The following is a description of a gene set: Human Gene Set: FLORIO_NEOCORTEX_BASAL_RADIAL_GLIA_DN Evolutionary expansion of the human neocortex reflects increased amplification of basal progenitors in the subventricular zone, producing more neurons during fetal corticogenesis. In this work, we analyze the transcriptomes of distinct progenitor subpopulations isolated by a cell polarity-based approach from developing mouse and human neocortex. We identify genes preferentially expressed in human apical and basal radial glia that lack mouse orthologs. Among these, ARHGAP11B has the highest degree of radial glia-specific expression. ARHGAP11B arose from partial duplication of ARHGAP11A (which encodes a Rho guanosine triphosphatase-activating protein) on the human lineage after separation from the chimpanzee lineage. Expression of ARHGAP11B in embryonic mouse neocortex promotes basal progenitor generation and self-renewal and can increase cortical plate area and induce gyrification. Hence, ARHGAP11B may have contributed to evolutionary expansion of human neocortex. species: Homo sapiens Genes down-regulated in basal radial glia (bRG) relative to apical radial glia (aRG), and up-regulated in both aRG and bRG relative to neurons. from publication Florio M, Albert M, Taverna E, Namba T, Brandl H, Lewitus E, Haffner C, Sykes A, Wong FK, Peters J, Guhr E, Klemroth S, Prüfer K, Kelso J, Naumann R, Nüsslein I, Dahl A, Lachmann R, Pääbo S, Huttner WB (PMID 25721503), and this is the list of marker genes: E2F8, GAS2L3, KIFC1, SLC35G2, CDCA2, MYBL2, KIF4A, KIF15, NUF2, CENPU, TRAIP, CKS2, FAM124B, SPAG5, HBG1, FBXO5, ARHGAP11A, IQGAP3 (IQ motif containing GTPase activating protein 3), CDCA5, TTK, DEPDC1, RAD51AP1, FAM72B, BIRC5, CCNB2, POC1A, BUB1B, TGIF1, EDNRB, TPX2, CENPK, HAPLN1, FOXM1, BRCA1 (BRCA1 DNA repair associated), PRC1, CENPL, SHCBP1, HBA1, BRCA2, CKS1B, AK4, ARHGAP19, ACBD7, TOP2A, ZWINT, KIF11, POGLUT3, LUM, SERTAD4, CCNA1, COL1A2, NUSAP1, TRIM59, HMGN2, NEMP1, MIS18BP1, TK1, VCAM1, PHGDH, KIF23, MKI67, LDLR, BUB1, CENPF, CKAP2, CENPE, CHEK2, PTTG1, TROAP, GRIN2A, SKA3, SGO2, CENPA, CDCA3, MCC, BLM, SEMA5A, NID1, TIMELESS, SGO1, APOD, FAM72D, MAD2L1, ESCO2, WEE1, TACC3, NDE1 (nudE neurodevelopment protein 1), KIF22, FANCI, ATP9B, DTL, CDC45, HMGB2, CDCA8, NCAPH, EMP1, TUBB6, CEP152, PARPBP (NCBI Gene Id 55010), DSN1 (DSN1 component of MIS12 kinetochore complex), UBE2C, CCNB1, LMNB1, PLK1, CENPM, ESPL1, PRR11, GINS1, SULT1C4, C5, ANLN, KIF20A, KNSTRN, DUSP10, KIF18B, ITM2A, KIF14, TFPI, GEM, UBE2T, RFTN2, MELK, FSTL1, EXPH5, CKAP2L, UGT8, IL32, KIF2C, EPB41L2, HSD17B11, KPNA2, PSRC1, AURKA, SKA1, LRP4, SPC25, CDK1, NSUN7, RACGAP1, NEK2, XRCC2, NDC80, SLC15A2, SPARC, KIF18A, PLK4, H1-1, CDC20, CIP2A, ANXA1, POLQ, PBK, EPCIP, PCDH11X, MSH5, TENT5C, FGFR2, MFAP4, PDGFD, HJURP (NCBI Gene Id 55355, Holliday junction recognition protein), FN1, GTSE1, MND1 (meiotic nuclear divisions 1), ANP32E, BRIP1, ANO5, RRM2, KNTC1, DLGAP5, NCAPD2, DEPDC1B, TMEM47, EXO1, HMMR, PRELP, MAP7D3, SERPINE1, PIMREG, ELMO1, ADGRF5, FAM111A, ASPM, HBA2, NCAPG2, FANCD2, TMEM255A, AURKB, CDKN3, FAM72A, SMC4